The following is a description of a gene set: from publication Chen Y, Wang X (PMID 31504780) Human Gene Set: MIR4486 Genes predicted to be targets of miRBase v22 microRNA hsa-miR-4486 in miRDB v6.0 with MirTarget v4 prediction scores > 80 (high confidence targets). species: Homo sapiens, and this is the list of marker genes: CDH1, RFT1, VKORC1L1, MEX3C, NKAIN1, UBE2O, PADI2, NUTF2, CNNM3, MOB3A, INMT, APOBEC3D, IQSEC3, RIMS4, DUSP18, ACP6, SLX4, KCNK2, QKI, PHF21A, AHI1, IFT122, SNX27, NF2 (NCBI Gene Id 654093), FBXO33, ACAP3, SZRD1, H6PD (hexose-6-phosphate dehydrogenase/glucose 1-dehydrogenase), TRABD2B, ARRDC3 (arrestin domain containing 3), SEC63, CACNA1I, NXF1, AKAP13